The following is a description of a gene set: Human Gene Set: GOCC_TIM22_MITOCHONDRIAL_IMPORT_INNER_MEMBRANE_INSERTION_COMPLEX A multi-subunit complex embedded in the mitochondrial inner membrane that mediates the inner membrane insertion of multi-transmembrane spanning proteins that contain internal targeting elements. In yeast cells, TIM22 is a 300-kDa complex, consisting of four membrane integral subunits, Tim22, Tim54, Tim18 and Sdh3, and a peripheral chaperone complex consisting of the small TIM proteins, Tim9-Tim10-Tim12. studied in species Homo sapiens, and this is the list of marker genes: TRMT10B, TIMM10B, AGK (acylglycerol kinase, NCBI Gene Id 55750), TIMM22, TIMM29, TIMM9 (NCBI Gene Id 26520), TIMM10